Given this list of marker genes Proca1, Oxa1l, Afg3l2, Afg1l, Tmem126a, here is a description of the gene set: Mouse Gene Set: GOBP_MITOCHONDRIAL_PROTEIN_QUALITY_CONTROL studied in species Mus musculus The chemical reactions and pathways resulting in the breakdown of misfolded proteins in the mitochondrion, which are targeted for degradation.